The following is a description of a gene set: The process in which the anatomical structures of the neural plate are generated and organized. The neural plate is a specialized region of columnar epithelial cells in the dorsal ectoderm that will give rise to nervous system tissue. species: Mus musculus Mouse Gene Set: GOBP_NEURAL_PLATE_MORPHOGENESIS, and this is the list of marker genes: Vangl2, Dvl2, Dvl1, Zfp568, Fgf8, Nog, Epb41l5, T, Htt